The following is a description of a gene set: Any process that stops, prevents or reduces the frequency, rate or extent of autophagic cell death. studied in species Mus musculus Mouse Gene Set: GOBP_NEGATIVE_REGULATION_OF_AUTOPHAGIC_CELL_DEATH, and this is the list of marker genes: Atg5, Atp6v0c, Bmf, Laptm5, Trem2